Given this list of marker genes Hmgb2, Pithd1, Tescl, Tesc, Gata2, Rcor1, Scin, Mturn, Rab7b, Thpo, Kdm1a, Faxdc2, here is a description of the gene set: species: Mus musculus Mouse Gene Set: GOBP_POSITIVE_REGULATION_OF_MEGAKARYOCYTE_DIFFERENTIATION Any process that activates or increases the frequency, rate or extent of megakaryocyte differentiation.